The following is a description of a gene set: Human Gene Set: REACTOME_POST_CHAPERONIN_TUBULIN_FOLDING_PATHWAY Post-chaperonin tubulin folding pathway studied in species Homo sapiens, and this is the list of marker genes: TUBB4A, TUBB2A, TUBA3C, TUBA8, TUBB3, TUBA1A, TUBA1C, TUBB4B, TBCB (NCBI Gene Id 126386), TUBAL3, TUBA3E, TUBA3D (tubulin alpha 3d), TUBB1, TUBB2B, TBCA, TUBB6, TUBA4A, TBCE, ARL2, TBCD, TUBA1B, TUBA4B, TBCC